The following is a description of a gene set: studied in species Homo sapiens Human Gene Set: HP_INTERMITTENT_EPISODES_OF_RESPIRATORY_INSUFFICIENCY_DUE_TO_MUSCLE_WEAKNESS Intermittent episodes of respiratory insufficiency due to muscle weakness, and this is the list of marker genes: SNAP25, CHAT, SLC18A3, TTN, MYO9A, SLC5A7, SYT2, COL13A1, SELENON, SLC25A1, MYH7, VAMP1, AGRN, CHRNA1